The following is a description of a gene set: Human Gene Set: GOBP_INNER_MITOCHONDRIAL_MEMBRANE_ORGANIZATION A process that is carried out at the cellular level which results in the assembly, arrangement of constituent parts, or disassembly of the mitochondrial inner membrane. species: Homo sapiens, and this is the list of marker genes: CIBAR1, MTX2, TIMM9, CHCHD3, TIMM10, OPA1, MICOS10, TIMM8A, CHCHD10, TAFAZZIN, LETM1, BCS1L, AFG3L2, TOMM70, PINK1, OXA1L, HSPA9, AGK, SLC25A46, MTX3, IMMT, UQCC3, TIMM22, ROMO1, TIMM10B, TRMT10B, CHCHD6, SAMM50, GHITM (NCBI Gene Id 27069), TMEM126A, OMA1, TMEM11, MICOS13, ADCK1, APOOL, COX18, TIMM8B, APOO, TIMM13, DNAJC11, TIMM29 (NCBI Gene Id 90580), NDUFA13, MAIP1, MICU1, MTX1